The following is a description of a gene set: Human Gene Set: GOMF_PEPTIDE_ANTIGEN_BINDING species: Homo sapiens Binding to an antigen peptide., and this is the list of marker genes: TAP1, CD209, HLA-E, CLEC4M, FCGRT, TRAV23DV6, HLA-DRB1 (major histocompatibility complex, class II, DR beta 1), HLA-C, TRBV12-3, HLA-DRB3, HLA-DQB1 (major histocompatibility complex, class II, DQ beta 1), TRAV12-1, TAPBP, HLA-H, SLC7A9, SLC7A5, HLA-DQB2, HLA-B, TRBV7-9, TRAV29DV5, HLA-DPA1, HLA-DQA2, HLA-DRB5, HLA-G, HLA-DPB1, TRBV28, TAP2, TRAV12-2, MAML1, HLA-DRA, TRAV12-3, HLA-DMA, HFE, HLA-DMB, HLA-DQA1 (NCBI Gene Id 7946), TRAV19, HLA-DRB4, DHCR24, TRAV8-4, HLA-DOA, TRGV9, TRGV3, HLA-F, HLA-A, HLA-DOB, B2M, SLC7A8